Given this list of marker genes NXT1, HSH2D, STIM2, H3-3B, TRIM26, COQ2, ORAI1, MFN2, TMEM127, ATOSB (atos homolog B), ADAM8, BCOR, SERPINB1, INPP4A, TM6SF1, RASSF5, LINC00324, EIF2AK2, TACC3, BANP, CLIC1, CDC37, BORCS5, RASGRP4, SDC2, PLOD1, PPP3CA, XPC, PRELID1, METTL22, DUSP1 (NCBI Gene Id 1843), MX1, MAP3K14, CRISPLD2, BCL11A, CD93, SPI1, R3HDM4, PDE4B, ADNP2, S100A4, SLC43A2, ATRN, ZNF276, CUX1, SLC40A1, SSH2, NUB1, SERPINB9, CNOT10, PPP4R3A, CAB39, TMEM248, CLTB, NUDT3, PXN, RRM2B, ETV6, ELF4, BOD1L1, KPNA2, GATAD2A, CTSS, FGR, SLC39A13 (NCBI Gene Id 91252), LRRC75A, PLCL2, BICRAL, JDP2, ATP2A3, DBN1, SETD1B, ARAP3, TNRC18, PRKAA1, CST3, SQOR, SIPA1L1, RUNX1, ABHD16A (abhydrolase domain containing 16A, phospholipase), GPR35, CTSH, MAML3, RHOF, RNF19B, DHCR7, RAB11FIP4, IFNAR1, VEZF1, NCKAP5L, TAOK3, ITPR2, PDCD4-AS1, SH2B3, DDX27, DBNL, SP110, MT1E (metallothionein 1E), ZSWIM6, TREX1, RGS19, LIMK2, C1orf162, CXCL16, ADAM19, MCEMP1 (mast cell expressed membrane protein 1), ZFP36L2, FLT1, CD53, ACAA1, NINJ2, SUPT4H1, HAUS4, PPM1M, MCL1, S100A6, DYSF, IER2, CD44, USP7, TPM3, DGAT2, PLCG2, SELL, KCTD20, COL17A1, MYH9, DDAH2, TRAK1, CHUK, NFKB1, FHOD1, PML, P2RY2, MYD88, USB1 (NCBI Gene Id 79650), RAB8A, GNAI3, QSOX1, GNMT, ANPEP, CERS4, IPO7, NOP10, PDLIM7, GMFB, FCHO2, DHRSX, CNOT6L, STX11 (NCBI Gene Id 8676), TGIF2, TLE4, MARCKSL1, MIR23AHG, FADD, HELZ2, SPAG1, VAV3, TNFSF13B, MX2, IL4R, TACC1, NLRC4, ECE1, PRR7, ADGRG3, RNF168, PDE7A, OASL, ZBED1, ITGB4, ICAM3, SRXN1, EFHD2, IFIT5, ABCC5, AMPD2, DNAJA1, SLC22A4, RGS3, LGALSL, LIMD2, ELF2, HPSE, HIGD1A, ARAF, DSE, LINC03122, NAB1, ADGRE2, YTHDC2, STX6, FRYL, SASH3 (SAM and SH3 domain containing 3), TATDN2, ZC3HAV1, UTRN, G6PD, RIGI, here is a description of the gene set: Human Gene Set: GSE37416_12H_VS_24H_F_TULARENSIS_LVS_NEUTROPHIL_UP studied in species Homo sapiens from publication Schwartz JT, Bandyopadhyay S, Kobayashi SD, McCracken J, Whitney AR, Deleo FR, Allen LA (PMID 22986450) We demonstrated recently that both constitutive and FAS-triggered apoptosis of human neutrophils are profoundly impaired by Francisella tularensis, but how this is achieved is largely unknown. To test the hypothesis that changes in neutrophil gene expression contribute to this phenotype, we used human oligonucleotide microarrays to identify differentially regulated genes in cells infected with F. tularensis strain LVS compared with uninfected controls. In order to examine the effect of F. tularensis on the neutrophil transcriptome, we performed microarray expression analysis on human neutrophils treated with F. tularensis subsp. holarctica live vaccine strain (LVS). Genes up-regulated in comparison of control polymorphonuclear leukocytes (PMN) at 12 h versus PMN treated with F. tularensis vaccine at 24 h.